The following is a description of a gene set: studied in species Homo sapiens The process of introducing one or more phosphate groups into a nucleoside monophosphate to produce a polyphosphorylated nucleoside. Human Gene Set: GOBP_NUCLEOSIDE_MONOPHOSPHATE_PHOSPHORYLATION, and this is the list of marker genes: AK5, AK6, AK4, AK2 (adenylate kinase 2), AK1, CMPK1, AK9 (adenylate kinase 9), AK8, AK7, CMPK2 (cytidine/uridine monophosphate kinase 2)